The following is a description of a gene set: Human Gene Set: HP_ABNORMAL_PLATELET_MEMBRANE_PROTEIN_EXPRESSION Presence of reduced amount of a membrane protein on the cell membrane of platelets. This feature is typically measured by flow cytometry. Abnormal platelet membrane protein expression species: Homo sapiens, and this is the list of marker genes: ITGA2B, GP1BB, GP9, SLC35A1, ITGB3, GP1BA